Given this list of marker genes UBA7, MFNG, CCT3, BAZ2A, RPS8 (ribosomal protein S8), RASAL3, ITPR2, SURF2, METTL26, TRIM28, REV3L, MAP4K2, MBTPS1, CNN3, ARMCX2, IL6ST, POLR1A, GNL3, TBCE, CYB5A, CCR7, ZBTB48, PDK1, SHISA5, IDH2, HSD17B8, RAMP1, BBS9, ILVBL, METTL3, ELOVL6, RPL3, CD96, INPP5B (inositol polyphosphate-5-phosphatase B, NCBI Gene Id 3633), RFLNB, MAP7, RPP14, MPP1, C12orf57, TMEM245, GSN, AKAP8L, FARSA, TCF7, HPCAL1, TRMT1, NFIX, GALNT11, UTP20, TEC, SATB1, WDR43, WDR46, DAXX, LTB, DCAF11, KCTD10, UBE3A, TSEN34, UBR4, RPAP1, BMAL1, NGRN (NCBI Gene Id 51335), CD5, ACAP1, TCF25, LEF1, PHF23, P2RX4, LLGL1, FRMD6, RPLP1, PRKAG1, MCCC1, SMYD2, TBCEL, DDIT4, EPHX1, ZFP1, FASN, CRY1, EXT1, NOP56, RACK1, ACP6, IKBKE, DPH5, VKORC1, CXXC5, DNAAF10, CANT1, NR1D2, VPS16, EVL, TARS2, ATG16L1, ICAM2, MEPCE, PPP1R14B, PTPN6, ENG, DDX47, ACP5, DALRD3, NPEPL1, ETS2, PDCD4, RGS10, DGKA, NEDD4L, GTF2I, GALK1, IFT25, BPHL, ID3, IPO4, FAAP20, COX7A2L, IRF7, FAM114A2, UNC45A, XPO6, NOP16, CDIPT, MRPL23, HMBOX1, AAMP, DDX3Y, ANAPC5, MLLT11, MED12, MAP4K3, TTC27, CLK2, ZMYM4, SLC44A1, STK10, RAD52, CD1D, HSD17B10, ABCG1, ENTREP3, SESN1, GPS1 (NCBI Gene Id 2873), AMPD3, CCNL2, TDRP, ST6GAL1, WDR74, LTA, SF3B1, PRKDC, ITGAE, POLR1C, KAT2A, CIAO1, RHOH, PELI1, DTX1, SPRED2, NPC2, STX6, POLG2, TERF2, ARHGAP45, AGAP3, XPC, PSME2, PPIC, KDM3A, HAGH, LYSMD2, PLEKHA1, SNRK, TTC3, ABCD3, SOCS1, DDX54, ABCC5, RERE (arginine-glutamic acid dipeptide repeats), GUCD1, IGHM, BRD3, NSMCE1, WDR75, RGL2, CNGA1, PRKCB, SLC12A7, TXK, SELL, CCND2, HEXA, BCL6, C19orf48P, RPS25, IL4R, KLF2, CD8A, MDN1, here is a description of the gene set: The only cells of the hematopoietic system that undergo self-renewal for the lifetime of the organism are long-term hematopoietic stem cells and memory T and B cells. To determine whether there is a shared transcriptional program among these self-renewing populations, we first compared the gene-expression profiles of naïve, effector and memory CD8(+) T cells with those of long-term hematopoietic stem cells, short-term hematopoietic stem cells, and lineage-committed progenitors. Transcripts augmented in memory CD8(+) T cells relative to naïve and effector T cells were selectively enriched in long-term hematopoietic stem cells and were progressively lost in their short-term and lineage-committed counterparts. Furthermore, transcripts selectively decreased in memory CD8(+) T cells were selectively down-regulated in long-term hematopoietic stem cells and progressively increased with differentiation. To confirm that this pattern was a general property of immunologic memory, we turned to independently generated gene expression profiles of memory, naïve, germinal center, and plasma B cells. Once again, memory-enriched and -depleted transcripts were also appropriately augmented and diminished in long-term hematopoietic stem cells, and their expression correlated with progressive loss of self-renewal function. Thus, there appears to be a common signature of both up- and down-regulated transcripts shared between memory T cells, memory B cells, and long-term hematopoietic stem cells. This signature was not consistently enriched in neural or embryonic stem cell populations and, therefore, appears to be restricted to the hematopoeitic system. These observations provide evidence that the shared phenotype of self-renewal in the hematopoietic system is linked at the molecular level. from publication Luckey CJ, Bhattacharya D, Goldrath AW, Weissman IL, Benoist C, Mathis D (PMID 16492737) Genes up-regulated in comparison of naïve CD8 T cells versus effector CD8 T cells. Human Gene Set: GOLDRATH_NAIVE_VS_EFF_CD8_TCELL_UP studied in species Homo sapiens